Given this list of marker genes Il6ra, Il6, Tyk2, Cbl, Socs3, here is a description of the gene set: part of: Interleukin-6 family signaling This event has been computationally inferred from an event that has been demonstrated in another species.<p>The inference is based on the homology mapping from PANTHER. Briefly, reactions for which all involved PhysicalEntities (in input, output and catalyst) have a mapped orthologue/paralogue (for complexes at least 75% of components must have a mapping) are inferred to the other species. electronically inferred by orthology from the curated human pathway Reactome Pathway: Interleukin-6 signaling species: Mus musculus